Given this list of marker genes Igkv1-99, Igkv11-125, Ighv8-8, Igkv1-110, Ighv7-3, Ptpn6, Ighv5-15, Ighv7-4, Ighv3-8, Ighv6-5, Iglc2, Igkv1-35, Igkv16-104, Ighv8-6, Cd22, Ighv5-12-4, Ighv5-2, Igkv2-137, Ighv8-13 (immunoglobulin heavy variable 8-13), Lyn, Ighv8-11, Cd79b, Ighv12-3, Igkv1-133, Ighd, Igkv2-109, Iglc1, Ighv3-3, Ighv8-4, Igkv1-131, Ighv3-4, Ighv6-4, Ighv3-6, Ighv16-1 (NCBI Gene Id 629812), Ighv3-1, Igkv1-117, Igkv1-122, Ighv5-9, Cd79a, Ighv5-12, Igkv1-88, Ighv7-2, Ighv8-5, Ighv13-2, Igll1, Ighv8-2 (immunoglobulin heavy variable V8-2), Ighv8-12, Ighv5-9-1, Ighv3-5, Igkv15-103, Igkv18-36, Ighv5-6, Igkv1-135, Ighv5-4, Igkv8-21, Igkv1-132, Ighv6-7, Ighv8-9, Ighv5-17, Ighv6-3, Igkv2-112, Igkv20-101-2, Ighv6-6, Igkv17-121, Ighv5-16, here is a description of the gene set: CD22 mediated BCR regulation species: Mus musculus Mouse Gene Set: REACTOME_CD22_MEDIATED_BCR_REGULATION